The following is a description of a gene set: Human Gene Set: REACTOME_ATP_DEPENDENT_CHROMATIN_REMODELERS species: Homo sapiens ATP-dependent chromatin remodelers, and this is the list of marker genes: SMARCA2, SMARCC2, SMARCD2, BCL11A, DPF1 (NCBI Gene Id 8193), DPF3, BCL11B, BICRAL (BICRA like chromatin remodeling complex associated protein), SS18, SMARCD1, PBRM1, ACTB, SMARCE1, SMARCD3, PHF10, ARID1B, SS18L1, DPF2, SMARCB1, ARID1A, BRD9, BCL7A, BCL7C, ACTL6A, BCL7B, BRD7, ARID2, SMARCC1, SMARCA4, ACTL6B, BICRA